Given this list of marker genes Rps6, Dph2, Dph6, Sumf2, F2, F8, Drg2, F10, Jmjd4, F9, Rccd1, Arsg, Proc, F7, Proz, Dhps, Pros1, Eef2, Sts, Gas6, Arsi, Dnajc24, Sumf1, Arsj, Riox1, Kdm8, Rps23, Arsa, Rpl27a, Jmjd7, U2af2, Bglap2, Fn3krp, Ggcx, here is a description of the gene set: part of: Post-translational protein modification electronically inferred by orthology from the curated human pathway Reactome Pathway: Gamma carboxylation, hypusinylation, hydroxylation, and arylsulfatase activation This event has been computationally inferred from an event that has been demonstrated in another species.<p>The inference is based on the homology mapping from PANTHER. Briefly, reactions for which all involved PhysicalEntities (in input, output and catalyst) have a mapped orthologue/paralogue (for complexes at least 75% of components must have a mapping) are inferred to the other species. studied in species Mus musculus